The following is a description of a gene set: The process in which an amino acid is transported across a membrane. Human Gene Set: GOBP_AMINO_ACID_TRANSMEMBRANE_TRANSPORT studied in species Homo sapiens, and this is the list of marker genes: LRRC8A, MFSD12, TTYH2, SLC38A1, SLC38A9, SLC7A8, ITGB1, SLC38A3, SLC7A9, SLC3A1, SLC7A7, CLTRN, SLC36A2, SLC15A4, SFXN1, SLC3A2, SLC7A6, ARL6IP1, SLC6A15, SLC6A12 (solute carrier family 6 member 12), GRM1, SLC38A11, SLC66A1LP, SLC6A14, SLC25A38, SLC7A10, SLC1A7, SLC38A5, SLC38A2, SLC25A2, SLC25A22, SLC6A11, RGS4 (regulator of G protein signaling 4), SLC7A5P1, SLC6A19, SLC38A7, PSEN1, SLC7A13, TMEM44, SFXN2, SLC6A20, SFXN3, SLC7A5, KCNJ10, TTYH3, SLC36A3, PRAF2, SLC38A6, SLC6A7, SLC7A3, SLC25A18, TSPO2, SLC25A13, SLC7A11, SLC25A12, LRRC8C, CTNS, TTYH1, SLC6A9, EPM2A, SLC7A14, TNF, SLC25A15, SLC6A18 (NCBI Gene Id 348932), SLC16A2, SLC25A29, SLC22A4, SLC47A1, SLC6A6, SLC6A5, ACE2, NTSR1, SLC16A10, SLC1A3, SLC6A1, SLC22A2, SLC32A1, SLC36A1, SLC7A2, LRRC8B, ATP1A2, SLC1A1, CLN3, SLC25A26, ARL6IP5, UCP2, SLC1A4, CLN8, LRRC8D, SLC11A1, SLC36A4, SLC17A7, SLC17A6, SLC7A1, SLC38A4, SLC43A2, SLC1A6, SLC7A4, SLC1A2, SEPTIN2, SLC1A5, SLC38A10, SLC17A8, RGS2, SLC6A13 (NCBI Gene Id 6540), PER2, SLC38A8 (NCBI Gene Id 648732), LRRC8E, GFAP, SLC7A5P2, SLC66A1, SLC43A1